Given this list of marker genes VEGFD (NCBI Gene Id 2277), PGF, FLT1, VEGFB, VEGFC, FLT4, KDR, VEGFA, here is a description of the gene set: Human Gene Set: REACTOME_VEGF_LIGAND_RECEPTOR_INTERACTIONS species: Homo sapiens VEGF ligand-receptor interactions